Given this list of marker genes CORO1B, WHAMM, DNAI3, WASF2, CTTN, WASF3, WASF1, GMFB, IQGAP2, PICK1, JMY, NCKIPSD, SNX9, GMFG, AVIL, here is a description of the gene set: Binding to an Arp2/3 complex, a protein complex that contains two actin-related proteins, Arp2 and Arp3, and five novel proteins (ARPC1-5). Human Gene Set: GOMF_ARP2_3_COMPLEX_BINDING species: Homo sapiens